Given this list of marker genes MTURN, MIB2, GABRR2, PAK1, S100A14, DNAJC7, RP1L1, PATZ1, SLC20A1, CARD6, RRAS2, APP, ZNF600 (NCBI Gene Id 162966), BEND5, AGK, MACROD1, KLHDC9, BBS2, NIPA1, LAIR1, FGFBP3, TET1, SCML4, RAPGEF4, SRSF12 (serine and arginine rich splicing factor 12), SLCO3A1, PIP4K2A, FITM2, MAGI3, EPM2AIP1, NDRG3, CA12, SBSN, ZFYVE28, MCTP2, CRTAM, C1orf21, TRIM28, RASGRF2, HDAC2, ENC1, DLEU7, GRAMD2B, AFG2B, DYRK2, OR2S2, EPC1, MRPL38, ITGB6, ADCY6, RMDN3, CASQ2, SELL, GRAP2 (GRB2 related adaptor protein 2), ZKSCAN1, STXBP4, NIM1K, ACP3, RSPO1, DAPK1, UBE3D, ALKBH8, DPH7, H1-2, TIMM8A, GPR18, ASB13, TULP3, MKNK1, BTG3, SPICE1, METTL16, PFKFB2, RAB3IP, IRF6, TCEAL8, CNN3, TDRP (NCBI Gene Id 157695), AMZ1, NFIX, CERKL, ADAT1, PMS2, MAGEF1, OVGP1, MGAT4A, RP1, ACSS2, ATP8B4, ALKBH4, RNF130, TRIO, HLA-DOB, SPSB1, ENPP4, CCDC82, BCL11B, DKC1, PKNOX1, TMIE, DPH6, PLEKHA1, ACVRL1, LYPD6B, LBP, LMO4, ADPGK, MYO1D, NCKAP5L, CYP2D6, AFDN, REXO1, ABHD15, GBP6, ARHGAP29, FBXL4, TOM1, TREML2, AMPD1, GUCA1B, ZNF830, ZNF212, XKRX, KCNMB4, GSTK1, CA11, TNNT3, SELENOP, RSAD1, IL11RA, RASAL1, RGS11, TNKS, AFF1, CCDC88A, MITF, CD163, TFAP2A, TTC27 (NCBI Gene Id 55622), IGSF21, CTPS1, TXK, TMPRSS5, SSBP2, PXYLP1, CDR2L, LYNX1, THNSL1, VIPR1, WDR89, GET4, PAK1IP1, TRMT1, EYA1, RGMB, KIAA0040, CNGA1 (NCBI Gene Id 1259), OASL, KLHL18, ADH1C, ACOXL, SLC16A5, TRUB1, ZNF672, RALGPS2, EIF3E, ARHGAP39, UBXN11, DET1, CAPN3, BPHL, ANAPC5, DBNDD1, INSR, ZBTB16, MSRB2, ATP1B1, PIK3IP1, ZBTB20, MCFD2, ZBBX, ST8SIA6, CDKN2A, MTX3, ZC3H3, USP36, THEM6, SGK3, MMUT, TTC28, PRSS46P, DENND11, GTF2I, NR2C1, TBC1D16, PAFAH2, GPD2, HBG2, SORCS2, PDK1, here is a description of the gene set: Conditional macrophage-specific PPARg knockout mice were generated on C57Bl/6 background by breeding PPARg fl/- (one allele is floxed, the other is null) and lysozyme Cre transgenic mice. PPARg and IL-4 signaling was analyzed on bone marrow-derived macrophages. Bone marrow of 3 mice per group was isolated and differentiated to macrophages with M-CSF (20 ng/ml). 20 ng/ml IL-4 was used to induce alternative macrophage activation and 1 uM Rosiglitazone (RSG) was used to activate PPARg. From each mouse 4 samples were generated: 1. M-CSF, 2. M-CSF+RSG, 3. IL-4 and 4. IL-4+RSG. All compounds were added throughout the whole differentiation process, and fresh media was added every other day. Control cells were treated with vehicle (DMSO:ethanol). After 10 days, RNA was isolated and gene expression profiles were analyzed using Mouse Genome 430 2.0 microarrays from Affymetrix. Genes down-regulated in bone marrow-derived macrophages with PPARG knockout: control versus IL4 and rosiglitazone. from publication Szanto A, Balint BL, Nagy ZS, Barta E, Dezso B, Pap A, Szeles L, Poliska S, Oros M, Evans RM, Barak Y, Schwabe J, Nagy L (PMID 21093321) species: Homo sapiens Human Gene Set: GSE25123_CTRL_VS_IL4_AND_ROSIGLITAZONE_STIM_PPARG_KO_MACROPHAGE_DN